Given this list of marker genes Thrb, Nlgn4l (NCBI Gene Id 100134948), Thra, Trpc2, Ar, Hexb, here is a description of the gene set: Mouse Gene Set: GOBP_COURTSHIP_BEHAVIOR The behavior of an organism for the purpose of attracting sexual partners. species: Mus musculus